Given this list of marker genes Ypel5, Tmem170, Ms4a13, Mmgt2, Dock10, Niban2, Fam107b, Ppm1e, Rnft1, Armc6, Cmtr2, Cgnl1, Prrc2b, Tgfb3, Ppp6r2, Mrgpre, Igf2r, Nrg2, Cfl2, Jmjd1c (NCBI Gene Id 71364), Kcnj10, Tspan6, here is a description of the gene set: Mouse Gene Set: MIR_1198_3P from publication Chen Y, Wang X (PMID 31504780) studied in species Mus musculus Genes predicted to be targets of miRBase v22 microRNA mmu_miR_1198_3p in miRDB v6.0 with MirTarget v4 prediction scores > 80 (high confidence targets).